Given this list of marker genes Flt1, Bak1, Hmgn1, Krtap21-1, Mir23a, Vegfa, Kdr, Fzd5, Bax, Klf4, Bcl11b, here is a description of the gene set: The process occurring during the post-embryonic phase whose specific outcome is the progression of the camera-type eye over time, from its formation to the mature structure. Mouse Gene Set: GOBP_POST_EMBRYONIC_CAMERA_TYPE_EYE_DEVELOPMENT species: Mus musculus